Given this list of marker genes Dlg1, Flna, Scn5a, Gja5, Kcnh2, Kcne1, Scn4b, Rnf207, Kcne2, Kcnn2, Cav3, Kcnh6, Kcnd3, Kcnj2, Scn2b, Snta1, Kcne4, Ank2, Kcne5, Kcnq1, Akap9, Zmpste24, Nppa, Nos1ap, Cacna2d1, Kcnj5, Kcna5, Cacna1d, Gja1, Wdr1, Scn1b, Kcnj8, Kcne3, here is a description of the gene set: Mouse Gene Set: GOBP_CARDIAC_MUSCLE_CELL_MEMBRANE_REPOLARIZATION The process in which ions are transported across the plasma membrane of a cardiac muscle cell such that the membrane potential changes in the repolarizing direction, toward the steady state potential. For example, the repolarization during an action potential is from a positive membrane potential towards a negative resting potential. species: Mus musculus